The following is a description of a gene set: studied in species Homo sapiens Human Gene Set: HP_ABNORMAL_NERVE_CONDUCTION_VELOCITY Abnormal nerve conduction velocity, and this is the list of marker genes: COL6A1 (collagen type VI alpha 1 chain), JPH1, SCP2, POLG, FLVCR1, WNK1, PNPT1, KIF1B, HPDL, UQCRC1, DCAF8, SBF2, MFF, PDK3, FXN, VCP, NFASC, TBC1D20, RAI1, GFM2, CHCHD10, IGHMBP2, PLA2G6, IDUA, MPZ, MATR3, PRDX3, GJB1 (gap junction protein beta 1), RAB7A, KIF1A, GALC, AIFM1, FBXO38, ERCC6, HSD17B4, ARHGEF10, SUCLA2, LITAF, CYP27A1, DEGS1, ABHD12, NEU1, DHX16, SBF1, TYMP, LMNA, ARSA, LTBP3, PLP1, TRIM2, LYST, NGLY1, EGR2, NALCN, SPTLC2, HYCC1, SOX10, MYH14, SACS, GJC2 (NCBI Gene Id 57165), CNTNAP1, SLC12A6, MEGF10, RRM2B, FBLN5, RETREG1, PSAP, BSCL2, LIG3, ITPR3, NOTCH2NLC, FBN1, PLEKHG5, DNAJC3, DNM2, PRPS1, YME1L1, ATP7B, LAMA2, TPI1, MED25, SIGMAR1, ERCC8, SAMD9L, ATXN1, TDP1, ATXN10, AARS1, HSPB1, MTMR2, MORC2, SETX, PRX (NCBI Gene Id 57716), NDRG1, FGD4, GARS1 (glycyl-tRNA synthetase 1), ERCC3, MFN2, FIG4, NEFL (NCBI Gene Id 4747), YARS1, SPTLC1, SLC25A15, PMP22, SLC5A7, REEP1, MTRFR, SH3TC2, PTRH2, PNKP, GDAP1, CTDP1, CCT5, PEX6, ATP11A, SCN9A, HK1, LRSAM1 (leucine rich repeat and sterile alpha motif containing 1), SORD